Given this list of marker genes CD1D, AP3D1, CD1C, AP3B1, CD1E, CD1A, CD1B, here is a description of the gene set: The process in which an antigen-presenting cell expresses lipid antigen in association with an MHC class Ib protein complex on its cell surface, including lipid extraction, degradation, and transport steps for the lipid antigen both prior to and following assembly with the MHC protein complex. The lipid antigen may originate from an endogenous or exogenous source of lipid. Class Ib here refers to non-classical class I molecules, such as those of the CD1 family. Human Gene Set: GOBP_ANTIGEN_PROCESSING_AND_PRESENTATION_OF_LIPID_ANTIGEN_VIA_MHC_CLASS_IB species: Homo sapiens